The following is a description of a gene set: studied in species Homo sapiens There are two major classes of polyunsaturated fatty acids (PUFAs): the omega-3 (n-3) and the omega-6 (n-6) fatty acids, where the number corresponds to the position of the first double bond proximate to the methyl end of the fatty acid. Omega-3 and omega-6 fatty acids are considered essential fatty acids. Humans cannot synthesize them, instead they are supplied through diet. Linoleic acid (LA, 18:2(n-6)), a major component of omega-6 fatty acids and alpha-linolenic acid (ALA, 18:2(n-3)) a major component of omega-3 fatty acids are the two main dietary essential fatty acids (EFAs) in humans. ALA and LA obtained from diet are converted in the body into their longer chain and more unsaturated omega-3 and omega-6 products by a series of desaturation and elongation steps. Metabolism of ALA and LA to their corresponding products is mediated via common enzyme systems. In humans ALA is finally converted to docosahexaenoic acid (DHA, C22:6(n-3)), and LA is converted to docosapentaenoic acid (DPA, C22:5(n-6)). The intermediary omega-3 and omega-6 series fatty acids play a significant role in health and disease by generating potent modulatory molecules for inflammatory responses, including eicosanoids (prostaglandins, and leukotrienes), and cytokines (interleukins) and affecting the gene expression of various bioactive molecules (Kapoor & Huang 2006, Sprecher 2002, Burdge 2006). Reactome Pathway: alpha-linolenic (omega3) and linoleic (omega6) acid metabolism part of: Fatty acid metabolism, and this is the list of marker genes: ELOVL3, ACSL1, ELOVL1, ACOT8, FADS1, SCP2, ABCD1, ACOX1, ELOVL5, ACAA1, ELOVL2, HSD17B4, FADS2